Given this list of marker genes SP1, CEBPB, AKT1, IL17F, TRAF3IP2, CEBPD, MAPK1, IL17B, IL17A, MAPK3, TRAF6, GSK3B, IL25, IL17C, MAP3K7, JAK1 (Janus kinase 1), IL17RA, NFKB1, IL17RB, IL17D, TRAF3, IL17RE, NFKBIB, IL17RC, IL17RD, PIK3CA, IKBKB, STAT3, RELA, MAP3K14, JAK2, IKBKG, here is a description of the gene set: Human Gene Set: WP_IL17_SIGNALING studied in species Homo sapiens IL17 signaling